The following is a description of a gene set: Any process that increases the rate, extent or frequency of the process in which cardiac muscle adapts, with consequent modifications to structural and/or functional phenotypes, in response to a stimulus. Stimuli include contractile activity, loading conditions, substrate supply, and environmental factors. Human Gene Set: GOBP_POSITIVE_REGULATION_OF_CARDIAC_MUSCLE_ADAPTATION species: Homo sapiens, and this is the list of marker genes: PPP3CA, MIR34C, MIR34B, TRPC3 (transient receptor potential cation channel subfamily C member 3), MIR214, APLNR, MIR199A1, MIR208A, MIR20A, MIR17